Given this list of marker genes SYT14P1, CPNE5, CPNE6, SLC23A2, SYT3, ITSN2, CACNG7, CPNE9, RIMS1, BCL11A, MUL1, SYT2, PRKN, SYT1, UNC13A, SPAG9, RASAL1, ATG16L1, RNF157, PLAA, NEDD4L, RIMS2, OSTN, SYT4, SYT17, SMURF1, here is a description of the gene set: Any process that modulates the frequency, rate or extent of dendrite extension. Human Gene Set: GOBP_REGULATION_OF_DENDRITE_EXTENSION species: Homo sapiens